The following is a description of a gene set: A reproductive process occurring in the mother that results in birth. studied in species Mus musculus Mouse Gene Set: GOBP_MATERNAL_PROCESS_INVOLVED_IN_PARTURITION, and this is the list of marker genes: Edn1, Cyp1a1 (cytochrome P450, family 1, subfamily a, polypeptide 1), Kalrn, Ldoc1, Ptafr, Bmal1, Nodal, Ccl2, Oxtr